The following is a description of a gene set: from publication Toker A, Engelbert D, Garg G, Polansky JK, Floess S, Miyao T, Baron U, Düber S, Geffers R, Giehr P, Schallenberg S, Kretschmer K, Olek S, Walter J, Weiss S, Hori S, Hamann A, Huehn J (PMID 23420886) We investigated at which stage of maturation commitment to a stable Foxp3-expressing phenotype takes place. We assessed stability of Foxp3 expression in thymic Foxp3+ Treg subsets of different maturity, defined by CD24 expression. Next we compared gene expression profiles of Foxp3+ Treg subsets (+) of different maturity (24lo, 24int, 24hi) and could identify a set of genes that were specifically up or downregulated in Foxp3+ Tregs, but not in Foxp3- conventional T cells, in a maturation-dependent manner. species: Homo sapiens Human Gene Set: GSE42021_TCONV_PLN_VS_CD24INT_TCONV_THYMUS_UP Genes up-regulated in T conv: peripheral lymph nodes versus thymic CD24 int., and this is the list of marker genes: PNN, PIK3CA, CELSR1, WBP11, HAGH, PPA2, RPL22, EPB41L4A-AS1, ITPR2, SLC25A4, MRPS25, TCP11, CLK1, HMCES, MRPL9, MAP4, IQGAP1, TCAP, TSPAN9, PEX13, PSMB8, SNRK, SRSF1, ACSL4, SCOC, TUBA3C, COQ5, CD86, RAMP3, TDP2, BPGM, MRPL30, RPL7, EPHA3, CETN1, DNPEP, PEPD, SF3B2, HLA-DRB1, TENT5C, SRSF10, HES1, XRCC6, ERGIC2, ARF4, NELFE, SNX14, MT3, SPA17, BMP4, POU5F1, MBD2, DYNC1I2, LY75, HLA-G, RNPEPL1, ORC6, CACYBP, S100A5, RAP1A, CSN2, TBL1XR1, ATP6V0B, NIPBL, PGAP4, PC (NCBI Gene Id 5091), MIX23, UBE2Z, FOXJ1, IMP3, ANKRD40, BTG1 (BTG anti-proliferation factor 1), GSN, SKI, RNF44, CD82, KMT2E, SIAE, MYH4, ITFG1, KIF3A, ISLR, MYCN, H1-3, TM7SF3 (transmembrane 7 superfamily member 3), SRPK3, TRIP12, LEPROT, TBC1D14 (TBC1 domain family member 14), KIFAP3, PARK7, RAB31 (RAB31, member RAS oncogene family), CDK1, CNIH2, ACTN2, BNIP3L, NDUFA12, WNT5B, SRCAP, FHOD3, PTTG1, SCGB1A1, FHDC1, USP33, RBM6, CAMK4, RUVBL1, TM4SF5, MPRIP, RSPH3, RNF138, SLC38A10, RTCB, IL15, PDLIM7, CEP350, GUCY1B1, CERK, ACADL, FGF5, IDS, RALA, CPSF3, COX6C, UEVLD, IGFALS, RAB18, ITGA6, FDFT1, CXorf38, CRAT, ELL2, FAM8A1, SCP2 (NCBI Gene Id 6342), YWHAQ, GTF2A2, MYH6, PRR5, RFK, CDH11, WNK1, CS, TM9SF2, ITGAV, CLIC4, RAB5A, COL9A2, DICER1, PCDHA11, TNFSF4, PIP4P2, EMC6, PSENEN, SMIM30, SMTN, TSHB, UBLCP1, NAE1, RCC2, MED11, FAAP20, TCF12, SOS2, KIF16B, RFC3, IREB2, PTPRN, ARL8B, SPTAN1, ANP32A, MYO10, SPAG7, PTPRB, RAI2 (retinoic acid induced 2), WDR1, CDC7, CTSF, PKN2, DPYSL4, PTDSS1 (phosphatidylserine synthase 1), METTL26, PIP5K1A, KRTAP19-5, EPB42, TRIM13, DFFB, FOLR1, INS, PDK3, H3C14, RCAN1, SURF1, ACADM, SLC52A2, SERPINB6, FBXW11, ANGPTL2, UQCRHL, RBM8A